The following is a description of a gene set: species: Mus musculus Genes predicted to be targets of miRBase v22 microRNA mmu_miR_7676_5p in miRDB v6.0 with MirTarget v4 prediction scores > 80 (high confidence targets). from publication Chen Y, Wang X (PMID 31504780) Mouse Gene Set: MIR_7676_5P, and this is the list of marker genes: Etv6, Dcaf7, Znrf3, Syt1, Acsm5, Elfn2, Lrrk1, Zfhx3, Tmem86a, Slc6a17, Kmt2a, Tent4a, Max, Rbms2, Mcidas, Neurl1b, Cd300e, Nectin1, Acss2, Pate2, Epha8, Pum2, Inppl1, Clic5, Slc5a9, Nat8l, Taf3, Map4k5, Epsti1, Gspt2, Gsdma, Plcb1, Rsad1, Tnrc6b, Unc80, Magea13, Lzts3, Nampt (NCBI Gene Id 68683), Pacsin1, Zyg11b, Maf1, Gatad2b, Zfp367, Krit1, Igdcc3, Kng2, Dab2ip, Bdnf, Sptb, Agap2, Zfp710, Rwdd1, Arih2, Klhl18, Sidt2, Itsn1, Arnt2, Ucn, Lhfpl4, Map1a, Notch4, Pcm1, 0610030E20Rik, Mapk9, Gabarap, Cdkn1c, Tlcd1, Letmd1, Fhip2b, Slc8a3, Sbk3, Adamts4 (ADAM metallopeptidase with thrombospondin type 1 motif 4), Ttn, Klhl9, Gspt1, Aph1a, Grm1, Nsd2, Nell2, Ptprm, Kng1, Tspan9, Cplx1, Srpra